Given this list of marker genes ATG5, STXBP5, GABRB2, DDX60, ATP1B1, RIMKLB, ARHGEF33, OLFM3, ATRN, FXYD3, IGF1R, LCORL, UBR3, ZNF25, ME2, MYO1D, SLITRK4, ARID1A, CNIH3, BTAF1, GDPD1, KCNV1, CCDC6, NTRK2, BNC2, SSBP2, MED10, OSBPL10, FLT1, ABR, PTAFR, DCC, IFT56, ACER3, CFAP97D1, HIVEP3, TRMT13, FAM120C, CREBL2, TRMT5, NCBP1, RCOR3, TCEA1, DPYD, QRICH1, AMMECR1, GPALPP1, ABCG1, ACLY (NCBI Gene Id 47), CADM2, PFDN4, SETD9, MAGEA3, SLC26A7, SGMS1, CALB1, SCARA3, MTREX (NCBI Gene Id 23517), CEP162, ADGRL2, FAT4, SUCO, CCDC170, DIS3, CAMTA2, MAGEA6, FOXI2 (forkhead box I2), PTBP3, MTF2, HOXC8, SYNE1, KCNAB1, RHOT1, ALG13, HLA-DRA, SKIL, GPM6B, SLMAP, LHFPL6, ANKRD31, PARVA, VPS13C, PNN, C1GALT1, GRAMD1C, DENND5B, THAP2, PUM1, EDA2R, B3GNT2 (UDP-GlcNAc:betaGal beta-1,3-N-acetylglucosaminyltransferase 2), UQCRC2, PSD2, ZBTB20, WASF1, WDR64, UBE4B, CDK8, CPSF2, DNMT3A, SMOC2, NKAIN3, ELL2, KANSL1L (KAT8 regulatory NSL complex subunit 1 like), RANBP17, GATA6, PGR, DCAF16, PPP4R2, here is a description of the gene set: Genes predicted to be targets of miRBase v22 microRNA hsa-miR-567 in miRDB v6.0 with MirTarget v4 prediction scores > 80 (high confidence targets). studied in species Homo sapiens Human Gene Set: MIR567 from publication Chen Y, Wang X (PMID 31504780)